Given this list of marker genes PCK1, NR1H3, RXRA (NCBI Gene Id 6256), NRIP1, RXRB, here is a description of the gene set: NR1H2 & NR1H3 regulate gene expression linked to gluconeogenesis studied in species Homo sapiens Human Gene Set: REACTOME_NR1H2_NR1H3_REGULATE_GENE_EXPRESSION_LINKED_TO_GLUCONEOGENESIS